The following is a description of a gene set: Any developmental process that results in the creation of defined areas or spaces within an organism to which cells respond and eventually are instructed to differentiate. species: Homo sapiens Human Gene Set: GOBP_PATTERN_SPECIFICATION_PROCESS, and this is the list of marker genes: HEYL, RELN, FOXN4, SMAD2, WNT2B, ZEB1, MIB1, TDRKH, FOXJ1, MYF5, COBL (NCBI Gene Id 23242), TDRD5, TULP3, TLL2, CDX2, WNT6, POU5F1, NEUROD1, WDR77, STC1, FGF8, NOMO3, DMRTA2, DZIP1L, OVOL2, SMAD6 (NCBI Gene Id 4091), FGF1, WDR19, SRF, IFT57, NOTCH1, DYNC2LI1, ACVR1, RING1, ASPH, EN1, RNF207, NOTCH2, NPHP3, FOXH1, FOXA1, KMT2A, TRAF3IP1, NOTO, HAND2, ZEB2, SYNGAP1, DKK1, FGFR2, DNAI2, ENKUR, SETDB2, MED12, DLX1, RIPPLY1, PCSK5, NOG, AIDA, TBC1D32, CHSY1, HOXD9, ABI1, YY1, APC2, HOXD8, LMX1B, MEIS2, FKBP8, LRP2, AP1B1, RARG, SIX1 (NCBI Gene Id 6495), FRS2, EP300, AXIN1 (NCBI Gene Id 8312), IFT52, RFX3, PROP1, ADGRG1, VAX2, PCDH8, ALG5, FST, MDFI, RNF220, PBX3 (PBX homeobox 3), ROBO1, HELT, RBPJ, PAX6, GDNF, HNF1B, IFT140 (NCBI Gene Id 9742), HOXD13, HIPK2, WNT1, DSCAML1, TRA2B, PBX1, WNT5A, CYP26C1, BBS5, IRX2, ARL6 (ADP ribosylation factor like GTPase 6), CRB2, PITX2, SOX18, IRX1, ROBO2, OTX2, EYA1, CER1, EXT1, HOXB1, NKX3-2, TBX3, DCANP1, CYP26B1, SMARCD3, PCGF2, RIPPLY2, HOXD12, BICC1, GLI1, ACVR2B, TGIF1, DAW1, IFT25, DNAH5, CRKL, TDRD6, FEZF1, SNAI1, BMI1, ALX3, DLX2, RIPPLY3, FOLR1, NKX3-1, FGF2, IHH, ACD (NCBI Gene Id 82538), PAX2, BPTF, SP8, ZIC1, CC2D2A, EFNB1 (NCBI Gene Id 1947), DVL1, ALX4, MFNG, FOXF1 (forkhead box F1), PIERCE1, NR2F2, MKKS, PGAP1, BBS7, LHX1, FOXC2, DLL3, GAS8, ENG, SOX17, PAX7, CRAMP1, DLL1, TIFAB, C3 (NCBI Gene Id 12266), PIERCE2, TMEM107, NTF4, DVL2, LHX3, BMP7, ETS2 (NCBI Gene Id 2114), CAPRIN2 (caprin family member 2), TBR1, LBX1 (ladybird homeobox 1), FUZ, PSKH1, CCDC103, ODAD3, SIX2, SEMA3F, TGFBR2, MAFB, HOXB2, HOXB7 (NCBI Gene Id 3217), ALDH1A2, MESP1, MEIS3 (Meis homeobox 3), TBX20, ACVR2A, HOXC6, NEK8, STIL, HOXB9, OOEP, CIROP (ciliated left-right organizer metallopeptidase), WNT8B, BMP5, CFAP45, NKX2-2, APLNR, HOXB5, FOXB1, NODAL, CCDC39, MLLT3, BMP4, FOXD1, DNAAF2, SFRP2, SMAD3, TBX2, ATM, HOXD3, C2CD3, BMPR2 (NCBI Gene Id 659), HOXC8, ASCL1, GRSF1, CRIPTO3 (cripto, EGF-CFC family member 3), BARX1, NBL1, TTC21B, FOXC1, ANKS6, TP53, SUFU, EMX2, IFT74, PLD6, UNCX, CELSR2, GBX2 (NCBI Gene Id 2637), DNAAF4, PRICKLE1, MYF6, MTF2, PTCH1, CDX1, GRHL3, MOSMO, DNAH11, CCDC40, FOXG1, MNS1, HOXA9 (homeobox A9), CDON, HIF1A, HOXC10, C1QA, TSHZ1, TCF15, OSR1, HOXC5, MEIS1, MEIS3P1, NRG3, HES7, TGFBR1, TBXT, RNF111, FBXL15, DISP1 (dispatched RND transporter family member 1), HES5, FGF10, CHRDL1, TBX5, NOMO1, RNF2, NCKAP1, MSX1, PKD2, NKX2-5, WNT2 (Wnt family member 2), WLS, LDB1, TLL1, CITED2, IFT172, FGFR1, POGLUT1, WNT8A, WNT3, WNT7B, HOXB6, ODAD2, ALX1, HOXA4, ISL1, WNT3A, BASP1, TDRD7 (NCBI Gene Id 23424), DDIT3, SHH, HOXD4, HOXA10, BMPR1A, RPGRIP1L, NRARP, TCTN1, PAX8, SMO, SMAD4, NDRG4, RTTN, MEF2C, LRP4, DNAAF3, DPCD, HOXA2, HHEX, CHRD, EGR2, PLXNA2, DRC1, TP63 (NCBI Gene Id 8860), HAND1, CIMAP3, INTU, AHI1, SHROOM3, HOXC4, BHLHE41, CLUAP1, TBX1, ARC, MID1, GPC3, TDRD1, LHX2, MMP21, DMRT3, DNAAF11, BCOR, TASOR, DNAAF1, BHLHE40, MICAL2, WNT11, SIX3, HEY2, VANGL2, HOXA11, MESP2, IFT122, GSC, GDF3, HOXB3, EMX1, POFUT1, CFAP53, CFAP52 (cilia and flagella associated protein 52), PRKDC, MKS1, GSX2, PALB2, CRIPTO, TMED2, NKX2-1, HOXB8, HOXA3, HES1, MEOX1, KAT2A, HOXC13, NLE1, HOXB4, DBX1, RAX, NKD1 (NCBI Gene Id 85407), SPRY1, GREM2, HES3, MSX2, NEUROG1, BMP1, DAND5 (DAN domain BMP antagonist family member 5), LFNG (NCBI Gene Id 3955), SIM2, CTNNBIP1, SEMA3C, KDM2B, GALNT11, OSR2, BTG2, KIF3B, PPP2R3A, DAAM2, DMRT2, HOXC9, CXXC4, EED, CTNNB1, HES4, DNAI1, LRP5, HIPK1, HOXA6 (homeobox A6), GLI3, AXIN2, SKI, GDF11, PCSK6, SFRP1, FZD5, LEF1, MSGN1, SOX1, ARL13B, TTC8, HES2, HOXA5, DCHS1 (NCBI Gene Id 8642), ITGAM, TBX18 (T-box transcription factor 18), CFC1, ASB2, RFNG, OTX1, TAF10, LEFTY1, EPB41L5, ODAD4 (outer dynein arm docking complex subunit 4), SMAD1, GLI2, IRX4, HEY1, SATB2, GATA4, LEFTY2, MEOX2, CFC1B, BMPR1B, GREM1, OFD1, FUT6 (NCBI Gene Id 2528), WNT7A, HOXA7, LAMA5, NRP1, HOXD11, SMAD5, APC, XRCC2, HOXC11, BMP2, C1orf127, AURKA, ZBTB16, EOMES, DOP1B, TCAP, HOXD10, CDX4, DLL4, SOSTDC1, PKD1L1, FEZF2, ACVRL1, GPR161, SSBP3, NCLN, FOXA2, NME7, HES6 (NCBI Gene Id 94875), ERBB4, AR, PBX2, HHIP, PSEN1, TBX6, MICOS10-NBL1, WT1, DYNC2H1, ATP6AP2, ZIC3, MEGF8, EDN1, IRX3, GATA5, NRP2